The following is a description of a gene set: The kinase activity of PTK6 is negatively regulated by both PTPN1 phosphatase, which dephosphorylates tyrosine Y342 of PTK6, and SRMS kinase, which phosphorylates PTK6 on tyrosine residue Y447. species: Homo sapiens part of: Signaling by PTK6 Reactome Pathway: PTK6 Down-Regulation, and this is the list of marker genes: PTPN1, SRMS, PTK6